The following is a description of a gene set: part of: TNF signaling electronically inferred by orthology from the curated human pathway Reactome Pathway: TNFR1-induced proapoptotic signaling studied in species Mus musculus This event has been computationally inferred from an event that has been demonstrated in another species.<p>The inference is based on the homology mapping from PANTHER. Briefly, reactions for which all involved PhysicalEntities (in input, output and catalyst) have a mapped orthologue/paralogue (for complexes at least 75% of components must have a mapping) are inferred to the other species., and this is the list of marker genes: Cyld, Tnfaip3, Mib2, Spata2, Fadd, Tnf, Usp21, Tradd, Usp4, Otud1, Tnfrsf1a, Birc3